Given this list of marker genes CEL, PLA2G1B, SERPINI2, REG1B, SPINK1, PNLIPRP1, CELA2A, CTRL, CTRB1, CELA3B, PRSS1, CLPS, CPA1, PRSS2, PRSS3P2, CTRC, GP2, CFTR, PNLIP, CPB1, CPA2, CUZD1, PRSS3 (serine protease 3), PDIA2, CELA3A, REG1A (regenerating family member 1 alpha), PNLIPRP2, here is a description of the gene set: Neighborhood of SPINK1 species: Homo sapiens Neighborhood of SPINK1 serine peptidase inhibitor, Kazal type 1 in the GNF2 expression compendium Human Gene Set: GNF2_SPINK1